Given this list of marker genes PRX, GDAP1, LITAF, MPZ (myelin protein zero, NCBI Gene Id 4359), PMP22 (NCBI Gene Id 5376), EGR2, here is a description of the gene set: Hypertrophic nerve changes species: Homo sapiens Human Gene Set: HP_HYPERTROPHIC_NERVE_CHANGES